The following is a description of a gene set: from publication Chen Y, Wang X (PMID 31504780) Genes predicted to be targets of miRBase v22 microRNA hsa-miR-6845-3p in miRDB v6.0 with MirTarget v4 prediction scores > 80 (high confidence targets). species: Homo sapiens Human Gene Set: MIR6845_3P, and this is the list of marker genes: TREML2, PCDH18, ZNF28, ZNF135, ING5, BRD2, HNF4G, PLP1, AMMECR1L, SLC24A2, ZNF701, USP37, IGF2BP1, LSAMP, LRRTM4, FPGT-TNNI3K, NFAM1, GATM, GBX2, TNFSF11 (NCBI Gene Id 8600), CCP110, PRDM4, MXI1, MAPK14, ZNF426, ZNF138, SLC12A5, PLXNA4, KDM2B, SPOPL, KCNB1, ZNF195, C22orf46P, CHD7, ZNF763, ZNF468, CPEB2, MRTO4 (NCBI Gene Id 94394), ZNF611, AGAP1, ZNF439, ADORA1, MEX3A, LPP, SNRK, ZNF781, CPEB4, CLCN3, ZNF559-ZNF177, PANK3, KPNA6, PLXNA1, ZNF440, ETV3, SH2D1B, AUTS2, ANK1, SLC6A17, PLD5, ZNF117, ZNF559, LAMC1, MOSMO, TRUB1, LHFPL6, PIGA, TPM4, AP4E1, ZNF676, EIF3L, FRMPD4, C1orf21, ZNF813, PLEKHM3, ZNF589, CNTNAP2, P2RY13, TNFRSF13B (NCBI Gene Id 23495), DTNA, ZNF765, ZNF493, TBC1D1, CCT6A, PIK3C2B, ARMC10, ZNF594, GTF2F2, ZNF181, HLF, KCND1, PAPPA2, AGAP3, ZNF268, ZFP1, CDX2, TVP23C, LRRC15, SLC9A9, C11orf68, RIN2, CNKSR2, ZNF808, TMPRSS11D, PPARGC1B, TASOR, ZSWIM9, TNRC6B, TNNI3K, PABPN1, CCDC57, TRIB2, ZFP90, ATP2B4, CYB561D2 (NCBI Gene Id 11068), IL1RAP, NDRG3, NHSL3, ZNF395, PLS3, DES, ZNF761, ZNF302, CHCHD3, DEGS1, FRMD5, GOLGA7, RC3H1, VOPP1, ENSA, GLUL (glutamate-ammonia ligase), ZNF124, KLHL8, SP1, ZNF677, SKP2, EVC, CLOCK